The following is a description of a gene set: from publication Chen Y, Wang X (PMID 31504780) Genes predicted to be targets of miRBase v22 microRNA hsa-miR-7844-5p in miRDB v6.0 with MirTarget v4 prediction scores > 80 (high confidence targets). studied in species Homo sapiens Human Gene Set: MIR7844_5P, and this is the list of marker genes: TM2D2, DAZ2, DAZ3, EPHA4, LSAMP, PHYHIPL, PPP4R2, RPS6KA3 (ribosomal protein S6 kinase A3), CCNE2, OTULINL, OTUD3, CRK, MEIOC, HNRNPF, SNX2 (sorting nexin 2), YWHAB, CPSF6, MAPK8, CAPZA2, FSD1L, CREBZF, LPP, SORCS1, PTX3, NFE2L2, CTTNBP2, XPO4, JADE3, FKBP14, REEP3 (NCBI Gene Id 221035), FXR1, PRKAR1A, DAZ4, ODC1, SKIL, DPH6, RTKN2, PRTG, DLL4 (NCBI Gene Id 54567), PDZRN4, ZNF281, MEA1, ADAMTS3, MAML3, ZMPSTE24, CELF2, NAV3, RAB33B, HMGCR, LRP12, CYB5R4, EBF2, RIMKLB, NAA30, KDM7A, ST3GAL6, ZNF24 (NCBI Gene Id 7744), ELOVL7, NDUFAF4, DOCK9, ZFHX4, CDH2, CPEB3, MEX3C, RNF182 (ring finger protein 182), RAB6D, ALDH5A1, GNG12, C1GALT1, ZEB1, UNC79, CDYL2, SYTL4, CDK19, RAB10, WASHC4, TCAIM, ABHD13, EMC1, ZIC5, FAM199X, ADNP, UCHL5, TRIP12, PHF20L1, ZEB2, AIG1, FOXF2, LHX8, RALYL, PPP1R15B, ATP6V1C1, KLHL15, SDHAF3 (succinate dehydrogenase complex assembly factor 3), MIER3, BBS5, POU4F2 (POU class 4 homeobox 2), HIF1A, HERPUD1, NAIP, SCARA5, ZBTB39, ELAVL4, C14orf28, EPN2, DAZ1, SNAPIN, STX7, ELK3, ZBTB10, RNF170, TMEM9B (NCBI Gene Id 56674), ZNF37A, IFI30, GORASP2, STRN3, ASAP1, PLA2G4D, MARCHF8, PLCD3, RPTN (NCBI Gene Id 126638), SPOCK3, STMN2, ATP7A, JARID2, P2RY1, KLHL28, STARD4, ABHD5, RAB2A, VIM, KLHL6, DBN1, CPOX, LDLRAD4, ELL, PRRC1, METAP1, PTPN22, KMT5B, MBL2, ZC3H6, CTSC, FRMD4A, ZNF385D, CATSPERB, PHLDB2, ZNF608, LRCH2, CFAP69, NAA50, SNAP25, ADD3, CARF, ABRAXAS2, ABHD2, ASTN2, GOLGA6L9, OGN